Given this list of marker genes GTF2IRD1, BCL11A, POGZ, TMEM147, KCNH1, TBC1D24, CDH11, SLC25A24, RAB3GAP2, DOCK7, PUS7, SOX11, PITX2 (NCBI Gene Id 5308), TGM1, LRP6, IFT56, NRAS, TFAP2A, SETD1A, DIS3L2, RIN2, EDNRA, PCDHGC4, SMS, SULT2B1, WDR26, FKBP6, AP4B1, RAB3GAP1, MDH1, MBD5, TAF4, RPS6KA3, GTF2I, ALOX12B, ELN, RBMX (NCBI Gene Id 8258), EDARADD, PLXND1, ZSWIM6, CDKL5, MAFB, TBL2, PAX9, HGSNAT, BMP2, SRCAP, PAX6, RPL10, FBXL4, CLIP2, TMEM270, GTF2H5, RAI1, CUL7, ALOXE3, QRICH1, EIF4H, SNRPN, NIPAL4, AHDC1, MED12L, ABCA12, BUD23, REV3L, RNU4-2, MYCN, FGD1, EHMT1, WNT10A (Wnt family member 10A), KCNK4, AP4E1, TCF3, NCF1, KIF7, IFT43, OCRL, ERCC2, CCDC8, RFC2, ERCC1, ADNP, UBAP2L, AXIN2 (axin 2), CHN1, ERCC6, ADAMTS2, ACBD6, IRX5 (iroquois homeobox 5), FHL1, METTL27, ESAM, FRMD4A, MGAT2, EDA2R, FOXG1, MSX1, WDR19, MAP1B, TBL1XR1, WNT10B, WDR35, DRG1, OBSL1, KCNMA1, CERS3, AP4S1, IFT122, KIFBP, ABHD5, CYP4F22, DENND5A, ANTXR1, DHX30, VPS37D (NCBI Gene Id 171020), KANSL1, H3-3A, PIGL, HSPG2, TFE3, LIPN, CREBBP, KMT2C, H4C5, MAN1B1, DNMT3A, CHAMP1, WT1, EEF1A2, FBXO11, SMG9, SDR9C7, SUMO1, NAA10, TGFA, FGFR1, MYO18B, EDA, MECP2, FOXC1, DBR1, IGF1R, MCOLN1, ASPRV1, SCARF2, BCAS3, POMGNT1, ATRX (NCBI Gene Id 6475), TNPO2, SMARCA2, ERCC5, GBA1, NFIX, LIMK1, MED25, BAZ1B, IRF6, ASXL3, EPG5, SMARCA4, CLIC2, EDAR, SALL4, DNAJC30, TFAP2B, IDUA, MED13L, HRAS (NCBI Gene Id 338029), BDNF, IFT52, PACS2, H4C9, AP4M1, STX1A, GTF2IRD2, SPECC1L, here is a description of the gene set: Eclabion A turning outward of the lip or lips, that is, eversion of the lips. species: Homo sapiens Human Gene Set: HP_ECLABION